The following is a description of a gene set: Mouse Gene Set: TABULA_MURIS_SENIS_KIDNEY_KIDNEY_COLLECTING_DUCT_PRINCIPAL_CELL_AGEING from publication Tabula Muris Consortium (PMID 32669714) studied in species Mus musculus, and this is the list of marker genes: Rrad, Ptbp3, Chd3, Rnf7, Macf1, Elf1 (E74 like ETS transcription factor 1), Picalm, Rps15, Eif3c, Plscr1, Ly6e, Rpl32, Serpinb9, Samd9l, Cyb5r3, Cxcl16 (C-X-C motif chemokine ligand 16), Entpd4, Nucks1, Rps21, Ssrp1, Rpl35a, Rps5, Tspan13, Rbis, Pam, Rbm25, Atp6v1g3, Itm2c, Rps27, Rpl37, Rps23, S100a11, Junb, Jun, Actb, Rwdd1, Pura, Rpl19 (NCBI Gene Id 19921), Mcl1, Sh3bgrl3, Mbd3, Id3, Ppp1r15a, Laptm4b, Slc35g1, Zcrb1, Ktn1, Gstm1, Ptma, Rpl38, M6pr, Prrc2c, Btc, Rps4x (ribosomal protein S4, X-linked), Xbp1, Rrp1, Casz1, Nectin3, Golga4, Rab5c, Rpl10, Spns2, Wbp11, Rpl21, Tnrc18, Eif5a, Resf1, Tmem254, Rbpms, Tpt1, Hnrnph1, Tnrc6b, Malat1, Avpr2, Ubxn2a, Twsg1, Cd74, Prkcd, Nfib, Cldn4, Tmem30b, Tuba1a, Mlec, Slco3a1, Irf1, Fam174b, Pdap1, Nenf, Btg2, Rps7, Cebpb, Srsf3, Klf2, Tmsb10, Ppfibp1, Rpl9, Zfp207 (zinc finger protein 207), Spag7, Hoxb9, Dusp1, Hoxb4, Flrt1, Smad7, Mapt, Rps3a1, Larp1, Cyba, Prxl2a, Ccnl1, Prelid1, Myl12a, Erdr1, Rps20 (NCBI Gene Id 67427), Vcf1, Rplp1, Elf3, Fam168a, Avpr1a, Bbx, Rbm3, Mat2a, Tmsb4x, H2-D1 (NCBI Gene Id 547343), Foxq1, S100a16, Arpc1b, Neat1, 6820431F20Rik, Rps28, Rack1, Ddx42 (NCBI Gene Id 78522), Ankrd11, Gadd45b, Hipk1, Pik3r1, Foxi1, Atp6v0d2, Aqp4 (aquaporin 4), Ier2, Tgif1, Zfp36, Nuak2, Sertad2, Hmgb2, Col18a1, Hnrnpa0, Zfp36l1, Samd4b, Ddx5, Hdgf, Tpp1, Coa3, Gnai2, Muc1, Rpl23, Ubxn1, Rps10, Bicc1, Hnrnpab, Rps19, Scg5 (secretogranin V), Prom1, Mvb12a, Tmed10, Fosb, Scin, Ncoa7, Apoe, Rpl31-ps12, Ppp2r3a, Cenpb, Rhob, Rplp0, Gcc2, Ddit4l, Ifi27, Eif1a, B230219D22Rik, Tmem45b, Lmo4, Celsr2, Btg1, Pgls, S100a10, Iqgap2, Nap1l1, B2m, Klf4, Cmip, Epcam, F11r, Vezf1, S100a13, Rpn1, Sox4, Rpl27a, Lasp1, Rtn4, Pak2, Tubb2b, Rpl35, Rps18, Jund, Stag2, Mier1, H6pd, Hepacam2, Cbx6, Irf2bpl, Ahnak, Miox, Eif5b, Cxadr, Tspan33, Kcnk1, Adgrf5, Jak1, Eps8, Fam20c, Ubn2, Calm1, Zfand5, 4930523C07Rik, Mal2 (NCBI Gene Id 223579), Syne2, Bcam, Fgfr1op2, Kmt2e, Gdf15, St13, Dnajb1, Eif4h, Pde3b, Zfhx3, Tsc22d4, Pcbp1, Krt8, H2-K1, Thoc2l, Stx16, Map1lc3a, Socs3, Set, Hook3, Tpr, Sfpq, Ndrg1, Ftl1, Cldn7, Rpl31, Mycbp2, Chmp2a, Ces1d, Tardbp, Brd4, Nfe2l2, L1cam, Ctsh, Rpl12, Aqp3, Tmc4, Rps8 (NCBI Gene Id 20116), Dstn, Lcn2, Atrx, Tsc22d1, Hbegf, Abhd14b, Rps15a, Synj2bp, Eml4, Tpm4 (NCBI Gene Id 72202), Slc4a9, Hsd17b11, Chka, Trim44, Adgrg1, Sptan1, Ociad2, Ywhah, Pfdn6, Ptp4a2, Rpl18a, Ccnd3, Cd24a, Rala, Rpl37a, Rps12, Flna, Ncor1, Capzb, Oga, Srsf5, Rpl39 (NCBI Gene Id 67248), Pnn, Actn4 (actinin alpha 4), Atf3, Zc3h13, Klhdc8a, Rpsa, Hsp90b1, Tapbp, Tgfbr2, Reep5, Prpf38b, Rab11fip5, Fos, Nfat5, 1300002E11Rik, Fhod3, Hspa1a, Plet1, Ywhab, Glis2, Mtdh, Tacstd2, Rpl13a, Napsa, Gpx4 (NCBI Gene Id 625249), Tspan9, Akap9, Spink1, Arid1b, Rpl22, Trib1, Scaf11, Chchd7 (coiled-coil-helix-coiled-coil-helix domain containing 7), Nol7, Litaf, Rrbp1, Tacc2, Slc48a1, Gpx3 (glutathione peroxidase 3), Ucp2, Pkn2, Rpl14, Rps27a, Lpp, Hmg20b, Rab11b, Car15, Efnb1, Myh9, Cd2ap, Krt18, Rpl5, Pappa, Exph5, Mark2, Timp3 (tissue inhibitor of metalloproteinase 3), Sort1, Golgb1, Dnajc5, Cirbp, Sltm, Hs6st1, Hnrnpc, Calm3, Arglu1, Rps24, H3f3b, Klf6, Rps29, Tuba1b, Agrn, Rps16, Clta, Rpl24, Foxp1, Rpl13, Rps17, Adamts1, Stub1, Rps3 (NCBI Gene Id 52418), Muc20 (mucin 20), Cdc42bpb (CDC42 binding protein kinase beta), Srrm1, Rplp2, Stc1, Dync1i2